Given this list of marker genes Edn1, Chat, Cacna1a, Pten, Cacna2d2, Nlgn3, here is a description of the gene set: Any process involved in the generation of rhythmic, synchronous synaptic inputs in a neural circuit. studied in species Mus musculus Mouse Gene Set: GOBP_RHYTHMIC_SYNAPTIC_TRANSMISSION